The following is a description of a gene set: studied in species Homo sapiens Genes predicted to be targets of miRBase v22 microRNA hsa-miR-8060 in miRDB v6.0 with MirTarget v4 prediction scores > 80 (high confidence targets). Human Gene Set: MIR8060 from publication Chen Y, Wang X (PMID 31504780), and this is the list of marker genes: CELSR2, VAPB, EBF3, C5orf24, FUT11, DACH1, TMEM216, DGKH, JARID2, TNMD, CLMP, GLI3, CERS6, CLDN1, POU2F1, LONRF2, SORCS1, MUC17, C2CD4A, CELF3, TMEM135, ARHGAP9, XKR4, MTCL2, ARID1B, MON2, ZNF711, MAPK6, FBXO21, MEGF10, CSMD3, TRDN, COX18, CLEC1A, ARMC1, EPSTI1, EBPL, NFYB, LRIT2, SLC30A7, NRIP1, ZNF566, SELENOW, RFX7, RUFY2, TFF2, CARNMT1, ZAR1, NXT2, MED30, JAK2, HBP1, PRH2, ASAP2, TMSB15A, ASXL3, NPAS2, ITGAV, KY, RNF2, CLDN12, TFAP2A, PPP2R3A, SYF2, CDK19, TMSB15B, SEMA5A, YWHAZ, OMA1, TET2, PDGFD (platelet derived growth factor D), KAZN, PCDH9, EPG5, ZC3H12B, KRAS, CPEB3, CST3, TCAF2, ANKS1B, CA10 (NCBI Gene Id 769), FAM149B1, OXR1, SLC23A2, MAPK8, ANKRD42, CDS2, MAF, FZD3 (NCBI Gene Id 7976), RBMS3, ARHGAP30, GUCY1A2, VBP1, GPR15, NBEA, CHL1, CLTC, ATP6V0D2, WWC3, QRICH1, FGF14 (NCBI Gene Id 317685), SLC8A3